Given this list of marker genes Slc17a7, Slc17a6, Ucp2, Slc17a8, Slc17a9, here is a description of the gene set: Enables the active transport of a solute across a membrane by a mechanism involving conformational change, where energy for active transport is derived from membrane potential if the solute is charged. Mouse Gene Set: GOMF_MEMBRANE_POTENTIAL_DRIVEN_UNIPORTER_ACTIVITY species: Mus musculus